The following is a description of a gene set: Reactome Pathway: Defective SLC5A7 in the neurotransmitter release cycle causes distal hereditary motor neuronopathy 7A (HMN7A) part of: SLC transporter disorders species: Homo sapiens The human SLC5A7 gene encodes a sodium- and chloride-dependent, high affinity choline transporter (CHT) transports choline (Cho) from the extracellular space into neuronal cells. Cho uptake is the rate-limiting step in acetylcholine synthesis, a neurotransmitter released at the neuromuscular junction (NMJ). Defects in SLC5A7 can cause distal hereditary motor neuronopathy 7A (HMN7A; MIM:158580). Distal hereditary motor neuronopathies are a group of neuromuscular disorders caused by selective degeneration of motor neurons in the anterior horn of the spinal cord, without sensory deficit in the posterior horn. The clinical picture consists of a progressive distal muscle wasting and weakness in the legs without clinical sensory loss., and this is the list of marker genes: SLC5A7